Given this list of marker genes Dpf3, Brcc3dc, Supt7l, Setmar, Fgf10, Xrcc1, Epc1, Brd8, Dpf1, C1qbp, Pcna, Chek1, Stk19, Zfp365, Tmem161a, Mgmt, Rnf126 (ring finger protein 126), Blm, Actr2, Actl6a, Bcl7c, Yy1, Ino80b, Brcc3, Npas2, Apbb1, Zcwpw1, Cul4a, Epc2, Rnf8, Dpf2, Morf4l2, Ep400, Kmt5c, Atxn7, Ing3, Atrip, Trim28, Top2b, Hsf1, Actl6b, Smarcc2, Kdm4d, Tigar, Fmn2, Smarca4, Actr5, Crebbp, Egfr, Taf7, Ercc8, Vps72, Skp2, Meaf6, Ppp4r3a, Phf13, Ppp4r3b, Cyren (NCBI Gene Id 78412), Supt20, Smchd1, Polq, Smarcd1, Kmt5b (NCBI Gene Id 225888), Rpa2, Taf5l, Fus, Slf2, Nbn, Tex15, Trp53bp1, Cbx8, Taf6, Sf3b5, Ccdc117, Rnf169, Rtel1, Eya3, Hdac10, Nfrkb, Taf5, Sirt7, Trrap, Bard1, Brd7, Taf2 (TATA-box binding protein associated factor 2), Helq, Sgf29, Fam168a, Tada3, Pnp, Eya4, Kat2a, Parp1, Mbtd1, Ino80d, Ager, Smarcc1, Kat5, Arid2, Wdr48, Sirt6, Cebpg, Recql5, Axin2, Smarca2, Ppp4r3c1, Usp1, Arid1a, Plk1, Senp3, Ppp4c, Tfpt, Rif1, Usp51, Taf10, Tada1, Shld3, Brca1, Eya2, Mre11a, Bcl7a, Babam1, Terf2ip, Abraxas1, Sirt1, Uchl5, Setd2, Usp22, Actr8, Smarcd2, Mad2l2, Dek, Uimc1, Ppp4r3c2, Ino80, Spire1, Cgas, Morf4l1, Ino80c, Csnk2a1, Rmi2, Eny2, Ruvbl1, Babam2, Actb, Khdc3, Eya1, Sf3b3, Foxm1, Riox1, Fh1, Mcrs1, Kat2b, Smarcb1, Pot1b, Yeats4, Dhx9, Phf10 (NCBI Gene Id 72057), Ier3, Prmt1, Ercc6, Rad51ap1, Mrnip, Ooep, Aunip, Timeless, Pbrm1, Kat7, Otub1, Rad52, Atr, Taf6l (NCBI Gene Id 75618), Helb, Pot1a, Rad51, Pias4, Ube2v2, Ube2n, Parg, Cdk9, Setd7, Rnf168, Parpbp, Nudt16l1, Spidr, Atm, Dmap1, Slf1, Kdm1a, Shld2, Hdgfl2, Fbh1, Shld1, Ogg1, Abl1, Nsd2, Smarcd3, Pml, Spire2, Parp3, Twist1, Peli1, Radx, Ddx11, Rps3, Taf9, Taf12, Prkcg, Ppp4r2, Fignl1, Mrgbp, Hmgb1, Kmt5a, Suv39h1, Prkdc, Bcl7b, Pnkp (NCBI Gene Id 76351), Hmga2, Ubqln4, Was, Wrap53, Atxn7l3, Fancb (Fanconi anemia, complementation group B), Ruvbl2, Smarce1, Klhl15, here is a description of the gene set: species: Mus musculus Mouse Gene Set: GOBP_REGULATION_OF_DNA_REPAIR Any process that modulates the frequency, rate or extent of DNA repair.